The following is a description of a gene set: species: Homo sapiens from publication Chen Y, Wang X (PMID 31504780) Human Gene Set: MIR548AU_3P Genes predicted to be targets of miRBase v22 microRNA hsa-miR-548au-3p in miRDB v6.0 with MirTarget v4 prediction scores > 80 (high confidence targets)., and this is the list of marker genes: KNOP1, LRCH2, SPCS2, GPRIN3, CDC25A, SCN2B, PARN, UTY, GNAI2, SURF4, RNF44, NAV2, NRIP3, KCNA1, DENND1B, EIF2S2, CDH13, ATF7, JAZF1, LYSET, QDPR, ARID4A, PKP4, RDX, TOX, FAM107A, ESYT3, INHBB, SLC27A4, FAM76A, XKR6, CYB5B, TAF4B, CRK, TRARG1, ATAD2B, PLAAT5, CAMLG, SCN1A, CALCR, FOXN2, LEF1, CAMTA1, ZFP28, NAV3 (neuron navigator 3), CDH9, PRKD1, MED4, PDE7B, OXSR1, CACNA1E, SLC25A27, RTF1, MGAT4A, PACS1, RNF128, UNC13C, SIRT1, HSPA13, RPGRIP1L, BNC2, CREB3L2, NUDT13, YTHDC1, MIER2, FCER1G, CADPS, ANKS1A (NCBI Gene Id 23294), ATP11C, COPZ1, ZZZ3, MDM4, PER2, NKTR, RRAS, BMP3, CRACDL, KCNH7, KITLG, MAPK4, JADE2, SMIM20, FAM210A, TBL1XR1, TNRC18, GPR22, SLC8A3, ATP5IF1, MTMR10 (myotubularin related protein 10), FGD6, ARNT2, LGI1, ZNF550, PGRMC2, SNX30, DIXDC1, ARHGEF3, RELN, UBE2QL1, RAP1GDS1, RAB21, LIN28B, E2F5, KIAA1217, FUT8 (fucosyltransferase 8), MEX3C, ADAM10, MYC, CA10, LHX2, HCN3, NPNT, ANK3, MPPED2, ZNRF3, FAM167A, ADAM22, EIF2AK2, MORN4, C9orf152, EDAR, ABRAXAS2, ADCY5, FLOT2, PTBP3, CENPS, RARB (retinoic acid receptor beta), NDC1, STK17A, SCN2A, CAPN5, HMMR, MBP, FAM117B, PKHD1L1, PHACTR1 (NCBI Gene Id 81705), ANP32A, FAM81A, SOX6, MTCL2, C5orf24, SRSF10, RDH11, UBP1, EEA1, ZDHHC17, PROSER1, RGS4, FMNL2, DGLUCY, SHOC2, CA9, ELAVL1, GAS1, PRR3, ATP1B3, MIDEAS, STRN3, C3orf70, RALGPS2, NIN, MKX, LUZP4, PPP1R11, C2orf69, AFF4, MTF1, FNDC3B, CBFB, FOXN3, PRKACB, DAB2IP